Given this list of marker genes CNTN1, GMPPA, HTR1B, STRBP, NRGN, TACR3, GPR83, APBA1, PJA2, APLN, KLK8, AGER, DNAAF4, ARC, TPGS1, ADCY5, KCNK4, GPRASP3, ADAM2, ZDHHC8, OBP2B, HTR1D, BRINP3, P2RX3, SEPTIN5, EFNB3, KAT2A, NKX2-1, GIT1, EP300, ADCY3, CHL1, DDO, AGTPBP1, MECP2, PGRMC1, PRNP, HOXB8, PAK5, TAFA2, BTG2, GRM5, ZFHX2, SGK1, CASP3, SOD2, GNG8, CHRNA6, HIF1A, HOMER2, BCL7A, SERPINF1, NLGN3, HOXD10, VPS35, DRD1, ABHD12, TAL1, SRF, DAB1 (DAB adaptor protein 1), VPS13A, SHANK3, PTN, GDNF, ID2, PTCHD1, PRKAR1B, NPS, ZNF212, SPTBN2, CPEB3, MFSD2A, CPT1A, PTGDS, FYN, CNTFR, BRSK1, HTR2A, KCNJ10, KLK14 (NCBI Gene Id 43847), TPBG, TTC21B, KRAS, TH, LRRTM1, MYG1, GBX1, CNP, PRKCE, SYT4, DMRTA1, ACVR2A, FEZF2, BORCS7, CSTB, PCDH17, TNR, PPP1R1B, ADARB1, PARK7, SRPX2, GM2A, DMRT3, CSNK1E, EPHA4, CXCL12, INSR, ADORA1, EIF2AK4, AVPR1A, LONRF2, NTSR1, CAMK4, GPR157, ARMCX5-GPRASP2, BSX, GATM, CLN3, GRN, GIGYF2, SLC1A3, SYNJ1, PCM1, SLC6A1, RMI1, ADCY8, UCN, BBS2, ATP6V1B1, DLG4 (discs large MAGUK scaffold protein 4), AIM2, CALB1, FOS, RELN, CHD7, PAFAH1B1, AGTR2, P2RX4, GAREM2, DCTN1, RNF180, PENK, CCK, PAK6 (NCBI Gene Id 56924), C1QL1, THRA, ADNP, BBS12, PPT1, AVP, TMBIM4, GAA, GPI, SEMG1, VDAC3, NPHP4, KCNA2, GRIN2A, RAG1, SLC1A1, CIC (capicua transcriptional repressor), FGF13, GPR176, ASTN1, AAAS, WDR47, THRB, GRIN1, ARF4, COMT (catechol-O-methyltransferase), GNB3, DKK1, SPTBN4, CAMK2N1, CNTN2, ITGA8, ALDH1A3, TMEM74, KIRREL3, SYT11, RXFP4, PYY, CIART (circadian associated repressor of transcription), RNF170, GABRB3 (gamma-aminobutyric acid type A receptor subunit beta3), SLC8A2, ASL, LDLR, LEP, PFKFB3 (6-phosphofructo-2-kinase/fructose-2,6-biphosphatase 3), MRAP2, HAND2, MFSD8, GNAT2, NTAN1, DNAH11, SYNGAP1 (NCBI Gene Id 8831), GPRIN3, SLC24A2, ADCY1 (NCBI Gene Id 449484), NR1D2, MBD2, STRA6, POMK, RAPGEF3, GCNT4, TREM2, CCL3, TBR1, SLITRK4, NR4A3, TMOD1, ZNF385A, SLC16A1, FSHR, LRRN4, ABCA2, PBX3, TTBK1, DCAF11, ADRB1, KAT2B, EIF4E, ATXN1L, RCAN2, GHRL, MYO15A, GAD1, INS, KMT2A, LEPR, PPY, DBH, NPAS2, FBXL20, ANKFN1, MUSK, CCND2, KCNK2, OXT, HCRTR1, SPG11, NDRG4 (NDRG family member 4), ANKH (NCBI Gene Id 7995), SCN11A (NCBI Gene Id 337933), ATXN1, KCNQ3, CNTNAP2, RPS6KB1, GABRG2, CASR, CHST10, CHRNB1, MC3R, CRHR1, ABL1, GHRHR, NFATC4, CNTNAP4, ASIC4, GFRAL, ORMDL1, CTNS, NPY5R, HTR2B, APBA2, VWA1, GNAO1, SCN9A (sodium voltage-gated channel alpha subunit 9), CSMD1, MC1R, TTC36, CHRNB2, EGR1, ALK, ACE2, SEZ6, CLN6, HTR1A, ARCN1, DRD4 (dopamine receptor D4), GHSR, PIRT, IAPP, ALS2, NRXN1, USP46, MAN2B1, TRPV1, GMFB, MKKS, UCK2, TUBA1A, SHISA7, SLITRK1 (SLIT and NTRK like family member 1), DRD3, B2M, TACR1, NPB, NMU, PLN, SPECC1, CREBRF, SLC6A3, RIC8A, GHRH, AHI1, SLC24A4, ABAT, SLITRK5, CHD8, FEN1, CCL11, HRH1, NPY, GCG, TSC1, ABL2, CLN8, PDE8B, CRBN, CEBPA (NCBI Gene Id 1050), NETO1, NEGR1, STRN, EPHB2, PDE1B, LRRK2, FOXP2, DTNBP1, SLURP1, NMUR2, THBS4, EN1, OXR1, QRFP (NCBI Gene Id 347148), SIX3, WFS1, MEIS2, PRLH, ITGB1, NEUROG1, IGLON5, BBS4, ADGRF1, C1QTNF4, RGS14, SELENOP, VLDLR, CAPN2, CUX2, SLC11A2, HTR2C (NCBI Gene Id 3358), NCOA2, GAL, ZFHX3, NPY2R, FEV, PITX3, SLITRK6, RASGRF1, FOXA2, NAGLU, CFAP20, TIFAB, TACR2, HCRT, TSPO, PTPRZ1, HOXA1, FXR1, NLGN4Y, KCTD16, APRT, CREB1, DRD5, ARRDC3, SNAP25, UBR3, TMEM63B, GRM7, HIPK2, AGRP, MCOLN3, MC4R, EIF4A3, PPP3CB, MCHR1, EGFR, HCN1, NLGN1, CRH, AFF2, UCHL1, GRIA1, ROGDI, YTHDF1, MEIS1, ATP7A, GALR3, OPRD1, BTBD9, GABRA5, HEXA, HCRTR2, JPH3, PRKCA, SGIP1, DMBX1, GPR52, MAP1A, CRHBP, LILRB2 (NCBI Gene Id 10288), NR1D1, NPY1R, NF1, MTNR1B, CDH23, EPM2A, KIT, ATP1B2, GLRB, NOG, NPAS4, ORMDL3, DSCAM, HTT, CX3CR1, KCNQ1, FADD, EXT1, GPR88, BRAF, STAT3, MDK, PLK2, TAS2R5, FZD4, ACSS2, CLSTN2, HPGDS, SHANK2 (SH3 and multiple ankyrin repeat domains 2), SLC2A4, PEX13, CHRNB4, SLC18A2, ATXN3, SPG21, ASIC1, NCOR1, GRIK2, HOXD9, MME, PYY3, NEDD9, PARP1, ZIC1, CHRNA5 (NCBI Gene Id 1138), MAPT, ITPR3, BRS3, HMGCR, ATP8A2, ETV5, NTF4, BGLAP, SOBP, SLC25A46, ELAVL4, BBIP1, ADAM11, UBE2Q1, DPP4, GRP, ADORA2A, ADM2, SGSH (N-sulfoglucosamine sulfohydrolase), GDF15, TRH, S100B, MTNR1A, OPRK1, GALR2, LMX1A, BCL2, SCN2A, CEBPB, EIF4G1, GLRA1, ASIP, GNAT1, SNCA, ARRB2, MORC1, ATP8A1, ZFY, PRKAA1, B4GALT2, NPC1, ELP6, FMC1, SLC6A4, DYNLRB1, VPS54, GRM1, NR2E1, NEUROD2, C12orf57, EDNRB, GLP1R, FIG4, FOXO6, EGR2, MBD5, EDDM3A, PUM1, TLR2, IFT20, LPAR5, INPP5F, CFAP69, ATAD1, CSF2, COL6A1, MAPK8IP2, IDO1, ADA, LYPD1, HTRA2, B4GALNT1, DVL1, ATP1A2, P2RX2 (purinergic receptor P2X 2), NLGN4X, NPTX2, SLC7A11, TAC1, P2RY1, CRTC1, MAFG, LCN2, PIANP, MYH14, PRKCG, REN, P2RX1, GNG7, JPH4, CLCN3, GLI3, NRXN2, SHANK1, CWH43, PRRT1, GBA1, ABCC8, FZD9, ZMPSTE24, NPHP1, OPRM1, MMP17, TACO1, PREX2, SERPINE2, KIAA0319, HDAC2, CACNB4, SCN1A, CLDN5, HELT, FGF12, ADRB3 (NCBI Gene Id 94406), RASD2, NR4A2, GLS, GUCA2B, TBX1, DACH1, SORCS3, GJB4, NTRK1, GIP, KLHL1, PIAS1, GRPR, MEF2C, PPARA, MINAR2, NDP, RETN, PRLHR, RPTOR, GRIN2D, APP, PER3 (NCBI Gene Id 8863), ADGRB3, FGF2, DEAF1, CARTPT, FKRP, LARGE1, DDHD2, SLC1A2, HEXB, NLGN2, AKT1, NPW, NPAS1, SLC8A3, BLOC1S6, PLCB1, EIF4EBP2, KCNAB1, SOD1, PMCH, NHLH2, SDK1, BRINP1, NAPEPLD, CHRNA4, BAIAP3, SLC4A10 (solute carrier family 4 member 10), CHRNA7, DCANP1, PAX5, MTA1, POU4F1, USP2, TANC1, MTOR, TMOD2, NAV2, PICALM, PTEN, HOMER1, HPRT1, NTRK2, B3GAT1, ABCA7, SLC12A5, GRID1 (NCBI Gene Id 54547), ETV1, LGMN, VPS13B, APOE, INSL5, GRIN2B, VDAC1, PRKAR2B, ARL6IP5, PRKN, EPS8, NCOA1, EFR3B, RCAN1, GPR37, THBS1, NRXN3, MAPK1, C3orf70, FOSB, OPN4, C14orf28, ITGA3, PPP1R9B, NCSTN, DRD2, SCN3A, GNB1L, CDK5, ITGA5, TMEM18, BBS1, PAIP2, GPR171, DERL2, NR3C1, FXN, CHRNA3, EHMT2, CEND1, ABTB3, TP53, PI3, TBCE, LGI4, NPSR1, FUOM, SLC17A7, BCHE, FOXB1, SNCG, GRM6, PSEN1, KCND2, AMFR, GRM2, here is a description of the gene set: species: Homo sapiens The internally coordinated responses (actions or inactions) of animals (individuals or groups) to internal or external stimuli, via a mechanism that involves nervous system activity. Human Gene Set: GOBP_BEHAVIOR